The following is a description of a gene set: Human Gene Set: GOBP_TELOMERE_MAINTENANCE_VIA_RECOMBINATION species: Homo sapiens Any recombinational process that contributes to the maintenance of proper telomeric length., and this is the list of marker genes: SMC6, SMC5, ERCC1, NSMCE2, RAD50, XRCC1, TEP1, RAD51C (RAD51 paralog C), XRCC3, TERT, RAD51, TERF2, BRCA2, ERCC4, RAD51D